Given this list of marker genes CDC20, FGF8, DLGAP5, IL1B, SPHK1, SKA1 (NCBI Gene Id 220134), ANAPC5 (anaphase promoting complex subunit 5), EDN1, AURKA, ANAPC11 (anaphase promoting complex subunit 11), CDC16 (NCBI Gene Id 8881), NUSAP1, IGF2, DMRT1, SKA3, PDGFB, PHIP, TGFA, PRAP1 (proline rich acidic protein 1), IGF1, EPGN, UBE2C, PDGFRB, IL1A, INSR, LRP5, HOXA13, EREG, ESPL1, DRD3, SH2B1, MAD2L1BP, CDC23, MAD1L1, EDN3, NUP62, SMPD3, INS, CD28, ANAPC7, BTC, CUL3, NSMCE2, RB1, EGF, TNF, here is a description of the gene set: Any process that activates or increases the frequency, rate or extent of mitosis. Human Gene Set: GOBP_POSITIVE_REGULATION_OF_MITOTIC_NUCLEAR_DIVISION species: Homo sapiens